Given this list of marker genes Pgbd1 (NCBI Gene Id 319207), Brd3, Zmpste24, Ush1c, Tfcp2l1 (transcription factor CP2-like 1), Slc9a5, Kcnip2, Tbc1d19, Rbm12b2, Elk4, Gata1, Zfp507, Sbds, Rab10, Vps13b, Csnk1g1, Foxq1, Abca6, Zfpm2, Qser1, Iqsec2, Slit2, Grb2, Cables2, Samd1, Npas4, Ccdc142, Yy1, Nr2c2, Klk4, Mfn1, Kif2a, Ywhae, Rrs1, Brdt, Sar1a, here is a description of the gene set: from publication Chen Y, Wang X (PMID 31504780) Genes predicted to be targets of miRBase v22 microRNA mmu_miR_378a_3p, mmu_miR_378c in miRDB v6.0 with MirTarget v4 prediction scores > 80 (high confidence targets). Mouse Gene Set: MIR_378A_3P_MIR_378C studied in species Mus musculus